The following is a description of a gene set: Mouse Gene Set: GOMF_DNA_EXONUCLEASE_ACTIVITY species: Mus musculus Catalysis of the sequential cleavage of mononucleotides from a free 5' or 3' terminus of a DNA molecule., and this is the list of marker genes: Aen, Pld3, Rexo2, Pld4, Isg20, Exo1, Polg, Dclre1c, Rad9a, Rad1, Exd2, Apex1, Exo5, Apex2, Tatdn1, Mgme1, Pold1, Dclre1b, Meiob, Dclre1a, Pole, Trex1, Mre11a, Aptx, Trex2 (NCBI Gene Id 24102)